Given this list of marker genes ADI1, RAPH1, AURKB, E2F1, SYN1, ITPK1, AGTRAP, CD180, NHP2, CSTPP1, MIER2, CA9, GLB1, WDR11, NCS1, ZGRF1, ZC2HC1A, TOP2A, SLC12A5, TMEM38B, AKIRIN1, DPY19L4 (dpy-19 like 4), ATXN1L, NMRAL1, UBE2L3, HCN3, IFT27, PCLAF, NCAPG2 (non-SMC condensin II complex subunit G2), ATRNL1, FETUB, ZAP70, SCARF1, CAMK2A, SNORD123, TBX5, FAM149A, UQCC2, CYBB, RUFY3, CAPN2, MAN2A1, ALPK2, DDX4, RBM47, DMD, EPM2A, BCAP29, ZRANB3, MCOLN3, NAALADL2, PLGRKT, NENF, ECI2, CSF2, CCNF, EPSTI1, FABP12, SLA2, MFSD10, NCAPD2 (non-SMC condensin I complex subunit D2), KYAT3, ANGPTL4, TMEM41A, EEF1G, SLC28A2, LTK, DARS1, ZMAT3, DKKL1, CFAP43, AIF1, NPR2, ACY1, VASH2 (vasohibin 2), MAMDC4, ENO4, LACC1, LARS2, TNS3, UPF3B, AMMECR1L, CD81, RPL24, LONRF3, OAS1, IPO11, ARB2A (ARB2 cotranscriptional regulator A), MRNIP, GUF1, DHRS3, CCNE2, ACAP3, TARS2, TRIM66, GCA, SEMA4B, SIX4, PPL, BIRC5, PRPSAP1, PIGN, OLFML2A, SLC25A13, BRI3BP, AJAP1, PDZD11, QRSL1, KIF24, PRXL2A, KCNK13 (potassium two pore domain channel subfamily K member 13), FAM222A, BCO2, PGLYRP2, TBC1D9, TJP2, CFP (NCBI Gene Id 5200), P2RY13, MPP1, DCTD, SMCO4, ACAD8, FAM167A, GGT1, MYOF, MXD4, GBP6, GCAT (NCBI Gene Id 23464), ERI2, LYSMD2, GALR1, HSD17B8, RAB9B, PTGR2, JPH4 (NCBI Gene Id 84502), OTUD7A, DTNBP1, HCK, TRPS1, CYP4F2, KRTAP15-1, ERN1, TP53INP1, MYPOP, RAB26, ADAM28, NDFIP1, SIRPA, SLC39A4, SPINT2, CYB5B, EVC, TFDP1, SLC66A1, KBTBD12, FUBP3, BUB1, PDXK, ITGB5 (integrin subunit beta 5), PLCD3, NBDY, CACNA1S, HDAC11, SYNE1, KLRD1, PBK, BIN3, MST1R, SPNS3, ENTPD4, CHURC1, FIGNL1, KCNK5, ASAP2, TRPM2, GCSH, POU1F1, SRSF1, CENPH, RTL8C, LGMN, IFT88, CACNA2D2, PAICS (NCBI Gene Id 647765), PPFIA4, WDFY2, SLC25A3, GJA4, SLC43A3, SLC38A9, SREK1, ZNF551, CTPS1 (NCBI Gene Id 1503), LAPTM4B, UNC93B1, ZBTB45, CDK5R1, NRP2, USP48, here is a description of the gene set: To analyze gene expression in in regulatory T cell precursors that develop in the absence of a functional Foxp3 protein as compared to that of normal regulatory T cells species: Homo sapiens Genes down-regulated in T reg: wildtype versus FOXP3 knockout. Human Gene Set: GSE6875_WT_VS_FOXP3_KO_TREG_DN from publication Lin W, Haribhai D, Relland LM, Truong N, Carlson MR, Williams CB, Chatila TA (PMID 17273171)